The following is a description of a gene set: from publication Yevshin I, Sharipov R, Kolmykov S, Kondrakhin Y, Kolpakov F (PMID 30445619) Genes containing one or more binding sites for (ZNF561) in their promoter regions (TSS -1000,+100 bp) as identified by GTRD version 20.06 ChIP-seq harmonization. Human Gene Set: ZNF561_TARGET_GENES studied in species Homo sapiens, and this is the list of marker genes: OSBP2, TASOR2, B4GAT1-DT, RFX1, CFAP52, HIRA, NDUFAF1, CACNB2, WDR70, NCAM1, CCT8, HDDC3, LINC00963, SGK1, MCM3, CCDC59, ITGB1-DT, FBXO27, LIG1, ZNF652, KRAS, TLN1, CHFR-DT, MANBAL, CDKN2C, C17orf75, CTTN-DT, GABPB2, CLUH, PTOV1, KCNK1, DOC2A, BBS10, CDK4 (NCBI Gene Id 92978), PPHLN1, RPL27, MRPL38, C1QL4, CNIH3-AS2, ADAP2, MAP4K5, STMND1 (NCBI Gene Id 90143), ENSG00000273828, BLTP3A, AP2A1, CHMP7, CAMKK1, DNAJC6, RNA5SP283, SPRYD4, AKT3, WEE2-AS1, TTC33, WTAP, TMEM202-AS1, CHFR, NOL8, HDGF, LINC01556 (NCBI Gene Id 731885), TMEM131, LRP6, ENSG00000232995, LDAF1, NSFL1C, PSMB8, GEMIN7, PTPA, KCNH1, VPS13B-DT, ENSG00000247416, CREM, PAFAH1B3, HERC5, SF3A3, PPIP5K2, TEFM, DLGAP4-AS1, LINC00933, HCG25, SEPTIN7P14, SCN4B, SMG7, CENPP, TATDN2, PPP4R3A, RABEP1 (rabaptin, RAB GTPase binding effector protein 1), L3MBTL1, RNF213-AS1, TUBGCP5, DDX54, PAWRP1, BPHL, PDZD2, CTSA, PDCD6P1, OAT, UIMC1, SMARCD2, DRAP1, IBA57, AMOTL1, ALG10, TUBGCP2 (tubulin gamma complex component 2), SIRT2 (NCBI Gene Id 22933), CACNG2-DT, PHLDA3, COX7A2, ANO8, PREX1, ZNF43, MGAT1, TBPL1, TLK2, CYP2E1, PHLDA1-DT, EML2, BMS1P4, SRRM2, RBBP7, GIPC1, ENPP3, TIMM22, IPO4, ATAD3A, OTUD7B, ZNF821, PDE8A, CPEB4, SEMA7A, FANCA, PROCA1, GTF2IP12, PPP6R3 (NCBI Gene Id 55291), NOP16, TDRP, TMEM41A, SH2B1, DTD1, KDM3A (NCBI Gene Id 55818), SEC14L1, CASTOR3P, SAMD11, MILIP, RNU2-2P, SEMA6A-AS2, FOXRED2 (NCBI Gene Id 80020), GRIN3B, GRAMD1C, POLR2I, MHENCR, ABCF3 (ATP binding cassette subfamily F member 3), DNAJC25-GNG10, SOAT1, ABCA2, ZNF668, ERF, MAN2A2, DYNLL1 (NCBI Gene Id 8655), SCNM1, DPYSL2, POFUT2, NEURL2, CDK11A, SELENOH, BRWD1, EIF4E2, TENM3-AS1 (TENM3 antisense RNA 1), RFTN1, VGF, HMGN2, ARHGEF10 (NCBI Gene Id 9639), TARS2, CFAP263, TRABD2B, CCNY-AS1, POU2F2, ZNF566-AS1, AVPI1 (arginine vasopressin induced 1), SLC25A4, TENM3, ZER1, MAP1LC3B, UBE2Q2P1, SETD1A, STX18, RNF43, RAB4A, CABLES2, CDKL1, LMAN2, PIPOX, PRDM15, THUMPD3, SFSWAP, TXNRD1, CLPP, CREBL2, CNIH3 (NCBI Gene Id 149111), ZBTB45, LRRC49, BMP8A, SNORD12C, LUC7L, NFIB, VPS51, HROB, SLC25A6, STAG3L2, CDK5RAP2, KRT8, COQ7-DT, PGAM5, CERCAM, VASP (vasodilator stimulated phosphoprotein), CREB3, ENDOV, AMDHD1, PTEN, COX16, DCTN4, VPS26C, YTHDF1, MBIP, CAPZA2, CMSS1, CCNY, HSF2BP, SCYL3, TNRC6B-DT, RCAN1, PDXK, KLHDC8B, RANBP9, ALG5, CHST11, CLN3, CALM1, ZFAS1, MED18, LTBP4, BMS1, CNOT1, STUM, PPP1R16A, LIM2-AS1, PCBD2, IFI44L, ZNF596, GOLGA3, WDR74, DENR, TTI2, SATB2, AP3S2, CENPT, MT2A, MEF2D, RGS7, PRCC, PDCD5, WTIP, SEC23B, IZUMO4, YAF2, CD2AP, ADAT2, ADCK5, MIR99AHG, NUBPL, TARBP1, ZSWIM9, FBXO31 (F-box protein 31), NAMPT-AS1, BAZ2A, CEP41, B4GAT1, STK4, TDRD7, POLR2C, MAP3K11 (NCBI Gene Id 4296), DPH7, TBP, PNMA2, ANGPTL6, MTHFD1L, PRPF18, NHS, COPS7A, PIH1D2, CBX4, CNOT3, TEF, TMEM101, ATP5PB, ZNF181, PRSS27, FLT3LG, ISM1, TSPEAR-AS1, FNBP1P1 (formin binding protein 1 pseudogene 1), LIMS1, ZNF609, SOX2-OT, BATF3, SSBP1, SUGT1-DT, ADPRHL1, CD2AP-DT, ZHX3, DLST, RNU6ATAC, CHCHD3, LEF1-AS1, CFAP74, WDR24, CDC42SE1, RNPC3-DT, BMI1 (NCBI Gene Id 648), MARCHF8, SEMA6A, MRPL3, TMEM104, CCDC88A, RRP15, LUZP1, IMPDH1, TANK, GCSH, PTPRS, SMG1P5 (SMG1 pseudogene 5), SLC31A2, ADAMTSL4, CDCA4, SNAPC5, GORASP2, REXO4, RRP1B, PRR4, KCNB1, YAP1, NUDCD3, SLC48A1, PCED1A, CMTR2, CCDC144BP, ARK2N, PEX3, RAI14, MRPS31, TPK1 (NCBI Gene Id 27010), COL4A5, DAXX, GAMT, PRECSIT, ARHGAP1, USP22 (ubiquitin specific peptidase 22), IRF9, NUTF2, FXYD3, LINC02846, ENSG00000263011, CASZ1, ADRM1, CSTB (NCBI Gene Id 1476), MET, KLLN, TIGD1, PGGT1B, USP31, ZNF646, DCLK1, TFDP1, CA13 (carbonic anhydrase 13), TMEM259, ZNF566, RANBP1, SLFN11, HLA-DMA, RITA1, CCDC159, TRMT2A, ATXN7L3B, RPL23AP53, FHIP1A-DT, METTL25, PAK1IP1, PHLDA1, APBB2, DST-AS1, TBCB, JMJD4, ACTR3, PDZD7, TP53BP2, MYNN, CACNG2, ITGB5, LLGL2, AKR1B1, ISOC1, ZNF790-AS1, VPS16, HAGH, RNU6-2, LINC01775, ECI1, HOXB9, RCOR3 (REST corepressor 3), LINC02136, CLCN7, GPC6, MIR4512, SH3BGRL3, RUNX1, NALT1, FBXW8, TMEM222, CHD3, ATL1, MRPL54, APBA3, ATXN7, TMEM9, CCNC, KIAA0513, FANCE, RUNX3, LRRC37A5P, NR2F1, TGIF2, STX8, COQ7, LMNB1-DT, MTG1, CRTC1 (CREB regulated transcription coactivator 1), ZKSCAN4, CRELD2, CTTN, SDCCAG8, MNS1, CHD2, TRIM45, SLCO4A1, RBIS, NAGPA, PTTG1IP, CBX3P4, TSPAN9, CEACAM7, HTR5A, MED23, LINC01359, ABHD13, FZD1, PYCR2, WDR77, TCF7, DST, SEC24B-AS1, TMEM199, ADAT1, BICD1, USP42, GABPB1, NUF2, GLI3, GPR146, GMEB2, ZNF652-AS1, PLK3, POC5, PNRC1, IST1, NPTN, STX18-AS1, PXK, TTLL7, GTPBP3, MRPS23, TSC22D1, PDIK1L, TTC3, RNPC3 (NCBI Gene Id 55599), PITPNM1, CACNA1A, PITX1, ZNF587B, SLC44A1, LAMP1, VPS72, PURB, PITX3, CFAP144, TUFM, CACFD1, VTRNA1-3, RAPGEF3, TAOK2, ACP2, BORCS5, MRPS14, ZNF501, BAX, TMEM134, PSMG1, MIR615, TANK-AS1, MED13, C7orf50, PIGP (phosphatidylinositol glycan anchor biosynthesis class P), HSP90AA1, RPA3, MARK4, FABP5P3, LHFPL5, CUL2, MFNG, PSMB9, TSFM, MIR7974, REX1BD, NUBPL-DT, HNRNPU, TRMO, CLN6, STK4-DT, HPS1, GAA, CYTH1, RNU6-92P, KCNH1-IT1, TAF5L, CUEDC2, DNAJC25, NUB1, ALG1, SAMD4B, SHB, NADK2, TMCC2, MTUS1, HMGXB3, KMT5B, RNASEH2A, GUSBP2, PHB2, CCAR2, CCDC192, DHRS12, ITSN1, POLR3B, TAS2R14 (taste 2 receptor member 14), CEBPA-DT, BEND3, ISY1, KATNB1, AGK, MRPL40, ALG10B, RPL29, UBE2I, TMEM179B, LINC01010, MAFG, DNAJB6, ZNF808, ENDOG, RNF115, ELK4, COL4A2, PCID2, LINC01275, STOML1, UBA52, FSTL3, LIG4 (NCBI Gene Id 3981), SRRM2-AS1, DYNC2I2, IGFL4, PAFAH1B1, RN7SKP114, LRP12, DUSP5, NBPF1, CAV1, VPS13B, MUS81, PDE12, GFRA3, ASIC1, KAT6A, SDHAF3, SLC35C2, MIR9-1HG, FZD5, LINC00205, MEF2A (myocyte enhancer factor 2A), BMS1P4-AGAP5, PEMT, TNRC6B, STX4, ABCA5, LRRD1, HAUS5, UMAD1, FGF19, VIRMA, SNORD13, PGF, KMT2E, LYSMD1, TYMS, VPS50, PKM, AARS2, BEND6, KCNH3, NSMCE4A, EFCAB2, DLC1, LINGO1, CLPSL2, ISY1-RAB43, SPNS1, FARP1, SNAPIN, SLC2A4RG, BANP, TTLL12 (NCBI Gene Id 23170), CTNND2, EIF2B5 (NCBI Gene Id 8893), POLR3C, NUS1, NR1H3, ZNF408, ACTL6A, FKBP4, EGLN2 (NCBI Gene Id 54750), ZC3HC1, PIM1, CCDC38, COL4A6, APC2, PTOV1-AS1, TLE6, ITGB1, UBAP2, RAB4A-AS1, DPY19L1, RNF38, LRRK2, FAT3, MOB3A, ITFG2-AS1, GARRE1, TMEM219, H1-10, PIGL, KMT2A, MIR6853, GCC2-AS1, TMEM94 (transmembrane protein 94), CUL4A, CEP170, RPL37, RGS5, C8orf82, MRPS34, GABPB1-AS1, GARNL3, ISLR2, GADD45G, ZNF850, SNAP47, URB2, VPS33A, PVALB, ASAP2, TJP3, FMR1-AS1, UBTF, KIAA1586, UBE2Q1, ZNF549, TOP3B, COL4A1, MBOAT1, DHDDS, KPNA1, XKR6, SRSF9, PPM1H, RNF185, PRC1, SLC16A10, ANKRD16, PDE4DIP (NCBI Gene Id 9659), PGBD5, ZNF256, FOXD1, HEXD, AGK-DT, NAMPT, NKAPD1, RBM17, KSR2, SLC33A1, FAF1, PCBP2, LINC01780, BRD2, EPS8, H4C8, PLCXD1, MIR4674, CRKL, TIGD6, SMIM12, VIRMA-DT, SEC24B, USP12, AP1G1, KDM7A, HEXA-AS1, RSPH3, MFAP3L, CDKN2AIPNL, ARB2A, MIR4521, SMIM8, FBH1, IBA57-DT, SEC11A, KRT18P12, VPS28, MIR1302-3, CASP8, SMG7-AS1, FAM133B, ZNF540, ELFN1-AS1, PDXDC1, NPAS3, SRGAP3, RCOR1, CACNG8, NAT9, ZNF700, BRF2, FRA10AC1, ZNF304 (NCBI Gene Id 57343), ODAD1, THAP10, HEXA, KMT2C, MCF2L, DHX16, LINC01778, MAML3, AURKAIP1, PHYH, ZNF787, ZNF511-PRAP1, EMG1, GLUD1P3, DPP9, LINC00240, RSAD1, ENSG00000267260, INTS2, NOTCH1, ZNF689, POLDIP2, HAUS5-DT, MTF2, LRRK2-DT, CBLL1, ZNF227, HOXB5, HUS1, DRG2, SMARCD3 (NCBI Gene Id 6604), NDC1, LINC00667, R3HCC1, SYNPO2, ZNF518A, CCNI, WIZ, ZNF136, NFKBIB, CASC9, EBF3, FHIP1A, SEC22B (NCBI Gene Id 9554), ARMH3, DMAP1, RNF103, PRR14, CFL1, OGFOD3, C11orf68, SEC13, TIMM50, SLX9, PTPN2, HDAC4-AS1, ALG12, MIR3928, PNMT, MRPS31P4, INTS12, RERE, FAM200C, SLC39A3, C6orf52, TMEM63A, FAM66B, PSMB1, SHKBP1, HS6ST3, RPS26, METTL3, FMR1, HDAC4, ELAVL1, SCYL1 (NCBI Gene Id 57410), PPP4C, PARP6, IFT52, ACOT11, MED12L, ANKLE2, RPL6, LINC02352, DPY19L4, MNAT1, SDAD1, GNB2, ABHD8, COIL, CLCN3, HEMK1, ING5, ZNF608, SH2D5, LMNB1, PHYHIP, CEP85L, TIAM2, ZNF92 (NCBI Gene Id 7645), PIP4K2B, AKAP17A, CCNE1, YWHAB, SRGAP1, JPX, RBPJ (NCBI Gene Id 51580), ZNFX1, JOSD2, HCG27, NUCKS1, ZNF511 (zinc finger protein 511), PRH1, CACNA1G (NCBI Gene Id 8913), GSTCD, TBC1D2, FAHD1, LINC01547, MRPL39